Given this list of marker genes CELSR3, ZNF576, CNN1, MMGT1, SLC25A25 (solute carrier family 25 member 25), RPL41, NDUFA10, SLC38A1, RUSC1-AS1, RRAD, CTC1, ADGRG4, MXD1, CLSTN3, MICALL1, TTLL10, CCDC148, CCNA2, DDX28, CBX8, KBTBD12, SPRY1 (NCBI Gene Id 91129), ACTR1B, MKNK2, ELL2, SEMA4C, ELOVL5, ZMYND15, HSD11B1, SYNGR3, CLDN7, C22orf31, TGIF2LX, KICS2, EHD1, ADAM11, GLI1, MARCHF10, ABI3BP, ACTL7A, NFATC1 (NCBI Gene Id 4772), SULT2B1, FAIM2, SULT4A1, GPRASP2, YTHDC2, CAPZA3, SESN3, DUSP10, FAXC, ZBTB37, NOL4, DEPDC4, CHD4, RPS2P45, PPP2R5B, RPRD1A, FEZF2, ALLC, KYAT1, ZMYM2 (zinc finger MYM-type containing 2), RBM18, PDGFA, ASB17, CRH, MYT1, DNAJC5B, GPM6B, TAF11, ESS2, ANGPTL2, RAB25, LMCD1 (NCBI Gene Id 29995), FLT1, SLC38A6, GEM, MTSS1, FGF12, RUNX1, IQGAP3, DOK1, CFTR, RBKS, SLK, PTHLH, GTF2F1 (NCBI Gene Id 2962), CHMP1B, TRAP1, ZNF516-DT, JUND, SPATA7, DNAJC1, CH25H, CSPP1, CELF3, AFF4, IFT43, SLN, DAPK3, SCRT2, SPATA2L, PPP1R15A, AP2A2, TENT4B, CTNND1, NCALD, PNMA6A (NCBI Gene Id 84968), RNF44, LOXL3 (NCBI Gene Id 84695), SPDYE1, DNTTIP1, ABR, KCNK18, PRSS12, MRGPRF, SLC44A5, TH, MAF, NDST4 (NCBI Gene Id 64579), KCNK7, NEBL, SLC35G3, PLCZ1, TAOK2, BARHL1, STAT3, ITM2B, NEUROD6, TLX3, GBP5, ST13, SPEG, PDP1, INTS7, WNT10A, CARTPT, IZUMO1, ITPRIP, VRK3, DUSP3, CD2AP, FAM81B, CDX4, CIMAP1C, TGIF2LY, DUSP1, NUP42, ABLIM2, NTS, GALNT15, CYSTM1, SGK2, ATP6V0C, WBP1L, ZBTB18, ZIM2, SRRM4, GPR22, RELA, SPOCK2, ABCE1, PEG3 (NCBI Gene Id 5178), NR2E1, ING4 (inhibitor of growth family member 4), MAP1LC3A, TEX14, FOS, MEX3D, RUNDC3A, IL22, CMSS1, CLDN6, ATL2, ANAPC10, BSND, PPP2CA, FAM131A, BNIP3L, THADA, ZNF367, CRX, DCDC1, AKIRIN1, CRLS1, AREG, IRS4, MAG, FSCB, NCDN, BABAM2, MANEAL, ZNF593, CLCN5, SPAG9, ATP5F1D, DAAM2, CREM (cAMP responsive element modulator), PRSS27, AHI1, UCN, TSPYL4, NR4A2, MMP12, OSBPL9, PAK1, ALS2, MYOZ2, DAAM1, MAP1B, CS, HS3ST3A1, RAD23A (RAD23 homolog A, nucleotide excision repair protein), WFDC3, MAOA (monoamine oxidase A), TMEM147, QPCT, ADAP1, RALGAPA1P1, STX5, ZNF184, POGK, IGF2R, SNAP25, F2RL2, LTBP1, SPAG6, AJUBA, SCHIP1, DNAI1, ADRA1B, STARD13, CXCL16, PITPNC1, ARIH1, TIPRL, PPP2R5C, DDX51, GLT6D1, IRF2BPL, KCNN2, ACAP3, AGO2, NF1, H4C5, P2RX3, ARHGAP30, FAM219A, LDHA, CPNE1 (NCBI Gene Id 8904), ITK, GTF3C1, BSDC1, HAS1, CYLD, AKAP3, TAGLN, CCL4, SIPA1L2, IQCF1, CCDC86, FAM53C, AKAP12, TSPAN7, CUZD1, TNFRSF21, MID1, DNAJC13, TNFRSF19, CREBZF, SGIP1, FOXD3 (NCBI Gene Id 373071), CDR2L, PHACTR3, SPACA7, ATP6AP1, EYA1, MRM3, HAND1, G3BP2, SCP2D1, PARD6A, RAI1, ID1, SCG2, ACTL9, BSCL2, SELE, HSP90AB1, RAB11B, RBM3, RBP5, SLC18A2, EPB41, PPARGC1A, TMEM39A, KCNF1, VGF, DHX36, DUS2, RARB, SH3BGR, LEMD1, TFDP2, HMGB4, PBXIP1, ZFAND2B, USP48, GRIA4, RNF14, CA12, KCTD8, ADNP2, RAB1A, SST, RNF7, NUP214, GLOD4, RELB, TNFAIP1, VPS37B, FLRT3, OSR1, MRRF (mitochondrial ribosome recycling factor), PNRC1, NT5C1B, PCSK2 (proprotein convertase subtilisin/kexin type 2), MYL6, PRICKLE2, RAB30, PRX, GABARAPL1, CSNK1G2-AS1, CAMK2D, CYP11A1, UBE2H, ACSBG2, SPI1, YWHAZ, DES, NOVA2, GRIN1, ZBTB11, TP53TG5, BRAF, NDUFB2, PTH, DNAJB4, PFAS, PKP4, STAG2, RUSC1 (RUN and SH3 domain containing 1), CD74, IKBKB, MYO7A (NCBI Gene Id 4647), SCN3B, CNN3, RND2, HAUS2, GNG3, GNL1, PER1, PAK6, LMO3, OLFM1, ARL4D, FAM174A, MCAM, HOXC4, IRX6, ZKSCAN5, FFAR3, TJP1, LRRN4CL, MAML3, CCDC54, PITX2, PTPRC, CCN4 (NCBI Gene Id 8840), DNAJC14, TBC1D32, THOC1, GNB4, ESM1, EFS, KCNA5, SLC3A2, PLN, TBL1X, GRK2, CDC42EP4, SPATA46, GPR3, EGFR, JUN, NUBPL, HCN4, SNCAIP, HAPLN1, SBF1, ADCY8, GAPDHS, CHPF, GPR42, ZNF335 (zinc finger protein 335), ADARB2, ZFP36L1, TPPP2, FIGN, LRRC57, NOC4L, TRAF4, PLCD3, STMN4, SYNGR1, PRR3, C1orf35, TPM3, NCK2 (NCK adaptor protein 2), FBXO34, PPFIBP1, COL6A3, RCAN2, CDK13, TACC2, RNF38, ZC3H10, DCTN1, C11orf87, SPRR1A, PACRGL, RHOJ, LIN54, UBQLN3, CBFA2T2, GARIN1B, KLF9, TSC22D1, PTPRU, CDS1, MAP3K13 (mitogen-activated protein kinase kinase kinase 13), C5orf46, RNF148 (ring finger protein 148), DENND2B, PHOX2B, CALCA, TGM1, RCE1, CYLC2, TGIF2, PSMD3, POLR2A, MYOCD, NPPC, CFL2, UBL4B, FGF6, PPP2R2A, C1orf116, DNAJC27, CENPE, DMP1, SEPTIN4, IL9, IL21R, DDX19A, ATG5, ZBTB4, TMEM59L, ZFYVE27, OGDH, SNX16, PNMA3, C1orf43, NUP98, MAPK10, UBQLN1, PDLIM3, DNAI3 (NCBI Gene Id 126820), GAB2, FBXW11, LGR5, GPBP1, ERCC6L2, MBNL2, TES, GASAL1, CHGB, SDHB, CACNA1G (NCBI Gene Id 8913), HIPK1, HS3ST2, DIO2, SCAMP5, SPMIP6, IFT20, PPM1A, TSC22D2, ZDHHC19, HDX, XPNPEP3, TP53INP2, ASPHD1, PAFAH1B1, UMPS, TMEM62, ANKS1A, MITF, ABHD16A, MAFF, MLF2, RCAN1, MXRA8, CCIN, IL13, IGF1, KCNK1, FAM186B, EEF2, FAM170A, ORAI1, CLCN4, GPR162, C18orf54, GLTP, SUV39H2, TPT1P8, PICALM, MAP9, DDX17, RPS29, IRX4, DLGAP4, EPHA2, UBAP1, HBS1L, QSOX1, AVPI1 (arginine vasopressin induced 1), MOB4, SIK1, RNF11, RIPOR1, PCSK1, OLIG2, FGF23, HOOK1, RAD51C, SENP2, PLEKHA1, CALM1, DTD2, here is a description of the gene set: species: Homo sapiens Genes having at least one occurrence of the highly conserved motif M9 TGAYRTCA in the regions spanning 4 kb centered on their transcription starting sites. This matches the ATF3 transcription factor binding site V$ATF3_Q6 (v7.4 TRANSFAC). Human Gene Set: TGAYRTCA_ATF3_Q6 Comprehensive identification of all functional elements encoded in the human genome is a fundamental need in biomedical research. Here, we present a comparative analysis of the human, mouse, rat and dog genomes to create a systematic catalogue of common regulatory motifs in promoters and 3' untranslated regions (3' UTRs). The promoter analysis yields 174 candidate motifs, including most previously known transcription-factor binding sites and 105 new motifs. The 3'-UTR analysis yields 106 motifs likely to be involved in post-transcriptional regulation. Nearly one-half are associated with microRNAs (miRNAs), leading to the discovery of many new miRNA genes and their likely target genes. Our results suggest that previous estimates of the number of human miRNA genes were low, and that miRNAs regulate at least 20% of human genes. The overall results provide a systematic view of gene regulation in the human, which will be refined as additional mammalian genomes become available. from publication Xie X, Lu J, Kulbokas EJ, Golub TR, Mootha V, Lindblad-Toh K, Lander ES, Kellis M (PMID 15735639)